Given this list of marker genes L3MBTL1, TDRD3, BAZ2A, BRD2, BRDT, THAP7, MBTD1, TP53BP1, TTLL12, BRD4, PWP1, NCAPG2, KDM4A, TAF1, MSL3, L3MBTL2, DPF2, NCAPD3, here is a description of the gene set: species: Homo sapiens A histone reader that specifically binds either to an unmodified histone H4 or a form modified by a post-translational modification on a specific residue. The most common PTMs on histones are methylation, acetylation and phosphorylation. Human Gene Set: GOMF_HISTONE_H4_READER_ACTIVITY